Given this list of marker genes MTRFR, COX6A1, KLHL9, TIMM50, PSMC1, MYO9A, MPV17, HK1, COG7, SYT2, LAMA2, TFG, TRIM2, ALG14 (NCBI Gene Id 199857), BIN1, CNTNAP2, OPA3, DCAF8, RILPL1, DNM2, CNTN1, NOTCH2NLC, PNPLA2, BICD2, GNE, MAG, SCO2, SNUPN, PIGB (phosphatidylinositol glycan anchor biosynthesis class B), ZC4H2, SELENON, FGD4, HADHB, CACNA1A, PMP2, RRM2B, IFRD1, NDRG1, APTX, PRPS1, TPM3, ITPR3, CD59, MYL1, SCYL2, CFL2, ISCU, ANXA11, ACO2, RNF170, SLC9A1, PIK3R5, MFN2, PNPT1, SLC25A46 (solute carrier family 25 member 46, NCBI Gene Id 91137), STIM1, SCN9A, CLPB, TPM2, NEFL, PRX, XRCC1, PEX2, WARS1, HSD17B4, VAPB (VAMP associated protein B and C), MYL2, KBTBD13, NEB, MME, TBCK, MEGF10, LMNA (NCBI Gene Id 7816), ASCC1, SURF1, INF2, DYSF, PEX11B, GNB4, SNAP25, TAMM41, SLC5A7 (solute carrier family 5 member 7), GBF1, RXYLT1, SMN2, KCNK9, SOX10, RTN2, PEX3, LRP12, EGR2, RNASEH1 (NCBI Gene Id 246243), ATP1A3, RAI1, HACD1, GAA, NARS2, ATP1A1, ATP1A2, REEP1, DHX16, GOSR2, KIF1A, HNRNPK, SQSTM1, ORAI1, VCP, VPS13A, MTTP, FKRP (fukutin related protein), PDK3, GEMIN5, B3GALNT2, COL12A1, COL13A1 (collagen type XIII alpha 1 chain), DPAGT1 (NCBI Gene Id 1799), TTPA, SLC12A6, TBCD, PAX7, SUCLG1, PIEZO2, PLA2G6, MCM3AP, FXR1, ATXN1, TWNK, TOR1A, SPTAN1, PLEC, RAB7A, B4GAT1, KLC2, AMPD1, PNKP, CCDC47, LAMB2, LPIN1, AIFM1, NEUROG1, TNNT1, KIF1B, SPTBN4, ACTA1, PEX10, PDSS1, POMGNT2, SLC5A6, GLE1, DST, CARS2, TRIM32, ALDH4A1 (NCBI Gene Id 8659), ATXN3, FAM111B, PEX1, SLC52A2, MED25, MYO1H, SBF2, ATP11A, SCN11A, MYOT, POMT1, SMN1, SACS, DAG1 (NCBI Gene Id 1605), ERBB3, CHCHD10, COL25A1, IGHMBP2, HMGCR, ENTPD1, XK, ITGA7, TTN, SBF1, SETX, ITPR1, KARS1, YARS1, MORC2, COQ4, PPP1R21 (NCBI Gene Id 129285), CAPRIN1, HADHA, PGM3, ALG1, TYMP, MYH14, RFC1, SIL1, PPP2R5D, LARGE1, RRM1, PYROXD1, COG8, NDUFAF2, FLVCR1, CNTNAP1, SNAP29, ARSI, ACER3, PEX5 (NCBI Gene Id 5830), GFPT1 (glutamine--fructose-6-phosphate transaminase 1), HSPB8, HINT1, ASAH1, JPH1, ALG2, DES (NCBI Gene Id 497658), GARS1, MRE11, HARS1, UGDH, PMM2, FXN, PRNP, MTM1, POLG, GMPPB, HSPB1, ABHD5, SLC1A3 (NCBI Gene Id 6507), MYF6, CAV3, OPA1, GCSH, GBE1, MT-TT, SYNE1, MPZ, GJB1, TDP1, FKTN, CRPPA, RMND1, PLEKHG4, ZFHX3, SLC25A4, MTMR14, DKK1, IBA57, AGRN, ATP6AP2, RYR1, POMK, GAN, WNK1, STAC3, LIFR, MYPN (myopalladin), DPYD (dihydropyrimidine dehydrogenase), PRORP, TECPR2, PEX14, CDK5, TCAP, SLC25A21, SAR1B, SH3TC2, PNPLA6, COASY, GDAP1, GIPC1, DNM1L, UBA1, COLQ, SCN10A, SPG11, LRSAM1, CADM3, ACOX1, FBLN5, ADCY6, SPTLC1, COL6A1, OCRL (OCRL inositol polyphosphate-5-phosphatase), DNAJC3, VAMP1, JAG1, KLHL41, POLG2, PDXK, DNAJB2, FHL1, PMP22, PLEKHG5, ERCC6, SPEG (NCBI Gene Id 729871), SLC25A1 (NCBI Gene Id 6576), COL4A1, CHAT, LGI4, TRIP4, ERCC8, FIG4, SIGMAR1, SLC18A3, ALG6, ERGIC1, PLAAT3, RETREG1 (NCBI Gene Id 96119), TRPV4, ERLIN1, AARS1, HSPB3, CRYAB, ALDH18A1, MAP3K20, MARS1 (methionyl-tRNA synthetase 1), FBXO28, ARL6IP1, POMGNT1, PEX12, POMT2, KCNJ18, here is a description of the gene set: Areflexia Absence of neurologic reflexes such as the knee-jerk reaction. Human Gene Set: HP_AREFLEXIA species: Homo sapiens